Given this list of marker genes Smarca2, Psmc6, Bsdc1, Sin3b, Tle1, Hadh, Nfix, Chd4, Hmgcr, Eif2ak2, Ptgr1, Zfp664, Kdm3b, Prpf40a, here is a description of the gene set: Cancer cells differentiate along specific lineages that largely determine their clinical and biologic behavior. Distinct cancer phenotypes from different cells and organs likely result from unique gene expression repertoires established in the embryo and maintained after malignant transformation. We used comprehensive gene expression analysis to examine this concept in the prostate, an organ with a tractable developmental program and a high propensity for cancer. We focused on gene expression in the murine prostate rudiment at three time points during the first 48 h of exposure to androgen, which initiates proliferation and invasion of prostate epithelial buds into surrounding urogenital sinus mesenchyme. Here, we show that androgen exposure regulates genes previously implicated in prostate carcinogenesis comprising pathways for the phosphatase and tensin homolog (PTEN), fibroblast growth factor (FGF)/mitogen-activated protein kinase (MAPK), and Wnt signaling along with cellular programs regulating such 'hallmarks' of cancer as angiogenesis, apoptosis, migration and proliferation. We found statistically significant evidence for novel androgen-induced gene regulation events that establish and/or maintain prostate cell fate. These include modulation of gene expression through microRNAs, expression of specific transcription factors, and regulation of their predicted targets. By querying public gene expression databases from other tissues, we found that rather than generally characterizing androgen exposure or epithelial budding, the early prostate development program more closely resembles the program for human prostate cancer. Most importantly, early androgen-regulated genes and functional themes associated with prostate development were highly enriched in contrasts between increasingly lethal forms of prostate cancer, confirming a 'reactivation' of embryonic pathways for proliferation and invasion in prostate cancer progression. Among the genes with the most significant links to the development and cancer, we highlight coordinate induction of the transcription factor Sox9 and suppression of the proapoptotic phospholipid-binding protein Annexin A1 that link early prostate development to early prostate carcinogenesis. These results credential early prostate development as a reliable and valid model system for the investigation of genes and pathways that drive prostate cancer. from publication Schaeffer EM, Marchionni L, Huang Z, Simons B, Blackman A, Yu W, Parmigiani G, Berman DM (PMID 18794802) Early prostate development genes (up-regulated at 6 h dihydrotestosterone) which are also up-regulated in normal epithelium vs high grade prostatic intraepithelial neoplasia (PIN). species: Mus musculus Mouse Gene Set: SCHAEFFER_PROSTATE_DEVELOPMENT_AND_CANCER_BOX1_UP